Given this list of marker genes SPIRE1, SPIRE2, FMN2, ORC4, WASHC5, here is a description of the gene set: Human Gene Set: GOBP_POLAR_BODY_EXTRUSION_AFTER_MEIOTIC_DIVISIONS The cell cycle process in which two small cells are generated, as byproducts destined to degenerate, as a result of the first and second meiotic divisions of a primary oocyte during its development to a mature ovum. One polar body is formed in the first division of meiosis and the other in the second division; at each division, the cytoplasm divides unequally, so that the polar body is of much smaller size than the developing oocyte. At the second division in which a polar body is formed, the polar body and the developing oocyte each contain a haploid set of chromosomes. species: Homo sapiens